The following is a description of a gene set: species: Homo sapiens Human Gene Set: GOBP_REGULATION_OF_TOLL_LIKE_RECEPTOR_4_SIGNALING_PATHWAY Any process that modulates the frequency, rate, or extent of toll-like receptor 4 signaling pathway., and this is the list of marker genes: PTPN22, ACOD1, SQSTM1, F2RL1, TAX1BP1, NR1D1, NR1H3 (NCBI Gene Id 113429), MIR200B, LYN (LYN proto-oncogene, Src family tyrosine kinase), LBP, PELI1, DAB2IP, NINJ1, TRIM32, WDFY1, CD14, LILRA2, TICAM2, TREM2, APPL2, MIR708, FLOT1, MIR20A, IFI35 (NCBI Gene Id 3430), MIR200C, ZNRF1, MIR146A, APPL1, BPIFB1, LTF, HMGB1, MIR149, RAB7B, MFHAS1, MIR140, TIRAP, PIK3R1, TNFAIP3